Given this list of marker genes BMPR1B, IHH, GDF5, FLNA, CANT1, BMP2, TGDS, here is a description of the gene set: Displacement of the 2nd finger towards the radial side. Human Gene Set: HP_RADIAL_DEVIATION_OF_THE_2ND_FINGER studied in species Homo sapiens Radial deviation of the 2nd finger